Given this list of marker genes PAX4, SLC2A2, HNF1A, SNW1, NEUROD1, CREBBP, MAML3, NOTCH1, IAPP, KAT2B, ONECUT1 (one cut homeobox 1), PKLR, PAX6, NKX6-1, FGF10, INS, AKT2, RFX6, MAFA, NR5A2, FOXO1, ONECUT3, GCK, MAML2, PDX1, FOXA3, HES1, EP300, FOXA2, AKT3, INSM1, MAMLD1, MAML1, KAT2A, NKX2-2, AKT1, HNF4A, HNF1B, NEUROG3, RBPJ, PTF1A, HNF4G, here is a description of the gene set: Regulation of beta-cell development Human Gene Set: REACTOME_REGULATION_OF_BETA_CELL_DEVELOPMENT species: Homo sapiens